The following is a description of a gene set: Human Gene Set: GOBP_DITERPENOID_BIOSYNTHETIC_PROCESS The chemical reactions and pathways resulting in the formation of diterpenoid compounds, terpenoids with four isoprene units. species: Homo sapiens, and this is the list of marker genes: AKR1C3, PRMT3, DHRS9, ALDH1A2, ALDH8A1, RDH10, CYP1A1, BCO1, RBP1, ALDH1A3